The following is a description of a gene set: studied in species Mus musculus Genes containing one or more binding sites for (Rcor2) in their promoter regions (TSS -1000,+100 bp) as identified by GTRD version 20.06 ChIP-seq harmonization. Mouse Gene Set: RCOR2_TARGET_GENES from publication Yevshin I, Sharipov R, Kolmykov S, Kondrakhin Y, Kolpakov F (PMID 30445619), and this is the list of marker genes: Cox18 (NCBI Gene Id 231430), Ddx39a, Usp36, Cd63, Tesk2, Zfp810, Mdc1, Tssc4, Tmppe, Npepps, Pigc, Ccdc158, Tent5d, Prkab1, Nol11, Zfp386, H2bc11, mt-Th, Prpf4b, Hdx, Ppp1r9a, Ccsap, Gnaz, Bspry, Terb1, Cux2, H2bc4, Srrm3, Acaa2, Mbd4, E530011L22Rik, Gm8113 (predicted gene 8113), Slc7a7, Chp1, Zfp286, Fat1, 3110082I17Rik, Cckbr, Rnf130, Ddx10, Tshr, Dctn4, Dnm3, Dhx8, Atp6v1h (NCBI Gene Id 98576), Dhrs7, Tmed3, Elovl4, Arih1, Nfic, Exd1, Hvcn1, Spp1, Dhcr7, Macrod2, 4921514A10Rik, Ppil3, Clec12a, Apela, Txnl4a, Gm15912, Rnf20, Ube2e1, Ccdc174 (coiled-coil domain containing 174), Rcor2, Cenpw, Rgs2, Fyn, Acot7, Arhgef1, Ipmk, Gria2, Lncenc1, Rcan1, Ift122, Chrna9, Gm9936, Tbc1d17, Shox2, Fnip2, Depdc1a, Gpm6b, D630036H23Rik, H4c6 (H4 clustered histone 6), Ubxn6, Nrxn1, Cox15, Rbmxl2, Surf6, Hexa, Zfp764l1, Gm13034, Gm40190, Zcwpw1, Immp2l, Chd2, Ddx4, Zfp606, Zc3h8, Wsb1, Rsrp1, Snupn, Il3ra, Sorbs2, Gm20033 (predicted gene, 20033), Nif3l1, Hirip3, Mir99ahg (NCBI Gene Id 77994), Wdr81, 4930505A04Rik, Meioc, Gm16853, Prdm11, Tcn2, Ndufaf4, Pnpo, 9130024F11Rik, Selenok, Letm2, D730003I15Rik (NCBI Gene Id 98614), Gm10829, Ccdc192, Scfd2, Plpp6, Gm37885, Urb2, Stmp1, Hmgxb4, Mir6403, Creg1 (NCBI Gene Id 433375), Zfp451, Gm15728, Gm26562, Supt4a, Gm13777, Cd82, Gm42722, Wdr17, Mpp3, Cmklr1, Krr1, Gm15545, Scarna17, Ndrg1, Chi3l1, Eddm13, Ldah (NCBI Gene Id 68832), Sall4, Gm5444, Mif-ps6, Dusp23, Nek4, Otud1, Gm25867, Tram1, Platr22, Ltn1, Clec4g, Fbxo8 (NCBI Gene Id 50753), Phb1 (NCBI Gene Id 18673), 1700121N20Rik (RIKEN cDNA 1700121N20 gene), Gm31881, Cyp2u1, Eif2b3, Eid1, Klhdc4, Dnajb11, Ttyh3, Spata6l, Rpl41, Amacr, Orai2, Ccdc38, Pnkd, Smap1, Cadm4, Megf11, Gtf2e2, Gm9884, Wdr4, Git2, Ift52 (NCBI Gene Id 99173), 1700026J14Rik, Coq8a, Slx4, Usp35, Med1, Msx3, Clk4, 2410003L11Rik, Zfand4, Nbea, Pofut2, Smim12 (NCBI Gene Id 80284), Amph, Gramd1a, Lrrc36, Slc35e3 (solute carrier family 35, member E3), Fam131a, Ramac, Rgs9, Ncam2, Kbtbd12, Mrs2, Atg16l2, Tspear, Cc2d1a, Fam219b, Mir1983, Slc25a39, Paxbp1 (PAX3 and PAX7 binding protein 1), Gpc2, Aacs, Gm16318, Golm1, Gpr176, Iffo1, Cul9, Chmp1b2, Gm12762, 9530082P21Rik (RIKEN cDNA 9530082P21 gene), Flrt3, Nrip3, Tppp, 1700007F19Rik, Apba3, Ntn1, Terb2, Rpa2, Mroh6, Cxxc5, Suclg1, Mrpl44, Prcc, Mir8099-1, Sh3tc1, Plk2 (polo like kinase 2), Polr3e, Rbm44, Gstt1, Sgip1, Naa40, Riox2, Nfatc2, Parp11, Rpp14, Fuca1, Mcm3, Cops4, B4gat1, H2bc21, Btn2a2, Traf2, Rpp40, Agbl3 (NCBI Gene Id 76223), Tasor, Epg5, Timm29, Psmb3, Fam217b (NCBI Gene Id 99103), Top3b (NCBI Gene Id 21976), Furin, 4930589L23Rik, Commd4, C330002G04Rik, Plch1, Lhpp, 4930515G01Rik, Gm13135, Gspt1, Ssr2, Rbm46os, Nr3c1, Amt, Ccz1, Gadd45g, Plekha3, Pla2g15, Traip, Sema4b, Tomt, Slc12a6, Cnnm3, Mul1, Ylpm1, Dbil5, Mir423, Cimip4, Rrs1, Fstl5, Apc, 1110015O18Rik, 1110059E24Rik, Hoga1, Gm34767, Stpg2, Zscan22, Ggct, Eid2, Gle1, Zcchc24, Tbx20, Rbm47, Zpbp2, Nr6a1, Pkd2l2, Atf7ip2, Rbmx2, Negr1, Dhx40, H2bc3, Brdt, Scp2, Mpv17l2, Rc3h2, Pigyl, Nufip2, Pip4p1, Slc5a8 (solute carrier family 5 (iodide transporter), member 8, NCBI Gene Id 216225), Tmem108, Gab2, Mei1, Rnase4, U2surp, Fem1b, Rlig1, Pms2, Wipi1, Rmnd1, 1700113A16Rik, Foxa3, Abhd6, A730013G03Rik, 5430405H02Rik, Chst12, Nuak2 (NUAK family, SNF1-like kinase, 2), Map2k7, Matcap1, Coro2a, Egfl7, Syce3, Hspb6, Mapk8, Nup43, Xpnpep1, Zfp251, Lypd4, Xrcc5, Dbr1, Cntnap5b, Nr1h3, Vps13d, Lpcat3, Mdm1, Cops7a, Glis2, Naa12, 4930445N18Rik (NCBI Gene Id 77085), Gm5067 (predicted gene 5067), Zfp87, 2310030G06Rik, 4930453N24Rik, Plekhg4 (pleckstrin homology domain containing, family G (with RhoGef domain) member 4), Cdipt, Zfyve16, 1700067G17Rik, Mcoln1, Tjp1, Hlf, Slc9a5, Gm14401, Actrt3, Fmc1 (NCBI Gene Id 66117), Srcin1, Gm15903, Rab37, Trim68, L3mbtl4, Pbx3, Tmed2, Nsrp1, Fbxw7 (NCBI Gene Id 68467), Pacsin1, Ywhab, Aif1l, Psma3, Gdpd4 (NCBI Gene Id 233537), C430039J16Rik, Yipf2, Ipo7 (importin 7), Zbtb34 (NCBI Gene Id 241311), Gemin4, Stk31, Sympk, Ddx52, Ccnb1ip1, Rars1, Brat1, Elf3, Adamts10 (ADAM metallopeptidase with thrombospondin type 1 motif 10), Ptpdc1, Sacs, Grm8, Tmem220, Zfp655 (NCBI Gene Id 72611), Tuba3a, Farsa (NCBI Gene Id 66590), Chaf1b, Scg3, 1700020N01Rik, Dtwd2, Dus1l, 1700064H15Rik, Slc39a11, Spata24, Sbno1, Ang, Ttll7, Dnajc1, Hcn1, Zfp827, Apex2, Cenpc1, Nutf2, Ezh1, Sf3b1, Eapp (NCBI Gene Id 66266), Gemin5, Ube2o, Dapk3, Dis3l, Mterf1a, Prr19, Sec23ip (Sec23 interacting protein), Piezo1, Wdfy1, Pitx3, Gm15564, Dmrt1i, Gm10222, Gm12758, Irak4, Elovl2, Epop, Cyb5r2, Adamts17, Etv4, Alms1, H3c8, Stard4, Cfap44, Odad4, Focad, Zbtb44, Gstk1, Pebp1, Syn2, Smc3, Rpf1, Sgf29, Ptprs, Gm10644, Ccdc126, Hdac2, Dohh, Shcbp1l, Nlrx1, Rabgap1l, Atpaf2, 2310074N15Rik, Eif3c, A830008E24Rik, Slc25a38 (NCBI Gene Id 208638), D030028A08Rik, Vps11, H2bc18, H2ac5-ps, Dact3, Yeats4, Calm3, Gm5129, Ankrd37, Nhsl1, 1700088E04Rik, Net1, Rhof, Kank2, Rbm46, Cmtr2, Agrn, Ccdc88a, Mir8104, Heatr1, Cfap251, Ppid, Slc9a8, Gdi2, Tdrd12, Otulin, Entpd6, Izumo4, 1700112D23Rik, Faap20 (NCBI Gene Id 67513), Gm11850, Zkscan5, Boll, Fam111a, Tefm, Rfxap, Wbscr25, 1810019D21Rik, H2ac20, Klhl11, Top6bl, 3110083C13Rik, Snx1, Nup205, 5330429C05Rik, Tmco1, Mns1, Mfsd4b3-ps, Ctnnb1, Zfp791, Pprc1, Sirt6, Gm10044, Rn7s6, Nol8, Pdlim1, Fbrsl1, Dnajc16, Wdr38, Polr3a, Atxn7l1 (ataxin 7-like 1, NCBI Gene Id 72174), Zfp956, Fzd3, Pdgfra, Thap12, Mrnip, Edrf1, Bmp6, Papss1, Arhgef2, Rbbp6, Mtres1, Akap11, Gm22973, Zng1, Cmtm6, Liat1 (ligand of ATE1), Pfas, Adsl, Gorasp2, Hmox2 (NCBI Gene Id 15369), Gm11398, Pde4a, Fhod1, 2700078F05Rik, Etfa, Akr1c19, Cnppd1, Osbpl5, 3110070M22Rik, 4833412C05Rik, Mipepos, mt-Tl2 (NCBI Gene Id 17736), Nup50, Polr2f, Evi5l, Ccdc138, Gm30238, Pex6, Tex12, Cited2, Ldhc, Hdac1, Ints2, 5830411K02Rik, Arhgap21, Bcas1, Mlf1, Ift70b (intraflagellar transport 70B), Odad1, Asf1b, Uggt2, Mypop, Wdr43, BB557941, Glrx5, Esrp2, Gstm1, Smg9, Slc23a4, Zmym6, Bin2, Emc7, St6galnac4, Syt7, Ccdc115, Bambi, Adad2, Spmip4, Chkb, Gm11335, Rab3a, Pts (NCBI Gene Id 19286), Adgra2, H4c2, Ccdc83, Nedd9, Ddx43, Il6ra, B230317F23Rik, Kctd19, H2ac6, Brinp2, Gaa, Ssmem1, H4c8, Zfp335os, Snca, Suz12, Snora73a, Gm14320, Trpm8, Ube2l3, Ric1, H2ac11, Gm11635, Dhx32, 4933433G15Rik, Plekha4, Slc7a5, Stk11ip, Raf1, Gm23119, Esd, 4930558J22Rik, Obox4-ps29, Nkain2, Txndc5, Dynlrb2, Mrps9, Slitrk5, Eef2k, Gm13136, Pex10, Nans, Scarb1, Pdlim3, Msantd5l, 4632404H12Rik, Gm5464, Pcid2, Naxe, Stam, Ap1s1, Rps6ka5, Gpr155, Dot1l, Gm11346, Zbtb17 (zinc finger and BTB domain containing 17), H3c6, Shroom3, Gm10638, Rasd2, Dhrs13, Smc5, A930015D03Rik, Eif2b5, Ints8, Abca17, Gak, Wbp4, Zfp788, Zfp747, Atxn7l3b, Sox30, Anxa7, Zfp809, Rnf187, Cebpg, 3110031N09Rik, H2bc6, Smyd3, Ncan, Kics2, Ehbp1l1, Carmn, Tcerg1, Sap25, Rbpj, Gm13889, Nmt2, Naa16, Hes1, Camk1, Inpp5f, Otulinl, Rnf220, Gprin1, Tysnd1 (trypsin domain containing 1), Slc31a2, Fscn1, Fam43a, Ino80e, Atp9a, Zfp770, Strap, Zc3h14, Tcam1, Gm22984, Afap1, Gm16170, Gm42109, Lactb2, Qtrt1, Ergic3, Gm12059, Tra2a, Ly6k, Spryd4, Cmc1, A930007I19Rik, Nagpa, Gmnn, Trim44, Rptor, Lrsam1, BB218582, Trpc4ap, Rrbp1, Izumo1, Abtb3, Itgbl1, Mycbp2, Armc9, Ntrk2, Dpm1, Cstf3, Clcn3, Tmx1, Col22a1, Scg5, Cimap3, Tor1a, Gm22792, Polr3h, Dctpp1, 4921539H07Rik, Hps1 (HPS1, biogenesis of lysosomal organelles complex 3 subunit 1), Nt5m, Hccs, Bcl2l12, Epb41l4b, Nkapl (NFKB activating protein-like), Adgrb3, Myo10, 4930558K02Rik, Cd109, Fam98a, Lyrm2, Mir707, Srxn1, Kbtbd6 (NCBI Gene Id 432879), Zfp558, H3c7, Snhg3, Ston1, Msl3l2, Kifap3, Meis2, Gm16283, Anp32e, Nsfl1c, Dmrtc2, Cetn3, Haghl, Gid8, Acsf3, Tspyl5, Rhbdd2, Nfasc, Camsap2, Spop, Kbtbd11, Sgpp1, Cops8, Parp2, H2bc7, Rdh11, Ints6 (NCBI Gene Id 73038), Mmachc, Pcdhga7, Cdc23, Cntln, Glra1, Tia1, Brme1, 1700008O03Rik, Mir5100, Sdhaf4, Zfp784, Eef1e1, Rad51ap2, H4c3, Plrg1, Armt1, Tanc2, Rpph1, Akr1e1, Stom, H2ac7, Trip4, Spmip7, Gm10941, Ido2, Qdpr, Cstdc2, Zfp184, Tmem209, Nop58, mt-Tl1, Dpy19l2, Dap, Nup210l, Tmcc2, Dus3l, S100a6, Bcl2, Hyou1, Asrgl1, Gjc1, Gm28047, Epha3, Timp3, Slc6a6, Chaf1a, Platr6, Tmem167b, Whamm, Mthfsd, Epb41l4a, Jmjd1c, Cfap74, Borcs5 (NCBI Gene Id 67774), Arf4, Zfp865, Tbrg1, Tob2, Rnf114, Rdm1, Ankrd55, B3galnt2, Pafah2, Gm7626, Gm42579, Gm15587, mt-Nd1, Cdkn1c, Zdhhc6, Ctdsp1, Slc33a1, Skic8, Lrrfip1, Stc2, Bend4, Zfp532, Hsd17b11, Ank1, Nceh1, Mir1945, 1700001L05Rik, Snapc1, Fmnl3, Gbp3, Gm5141, Ccdc107, Gm36211, Ubtf, Tmem109, Ccdc15, Flvcr2, Gm57488, Cenpp, Btbd18, Psmb2, Pank3, 1700021P04Rik (RIKEN cDNA 1700021P04 gene), Fyttd1, Atp4a, Stx17, Hnf4g, Slx4ip, Gm15645, Cnot8, Ccar1, Akip1, Cacng3, Tex14, Duxf1 (double homeobox family member 1), 1700018B08Rik, Fgd4, Gid4, Vwc2l, Myef2, Znrf2, Arid1a, H4c9, Scamp5, Bcl7b, Tipin, Vhl (NCBI Gene Id 22346), Cdk20, Gtf3a, Rnf212, Glra2, Ppp1r3c, Gm16270, Ephb1, Rnasel, Asb7, Gnpda2, Pdik1l, Ndrg3, Rcbtb1 (regulator of chromosome condensation (RCC1) and BTB (POZ) domain containing protein 1), Arl8b, Pum2, Vim, Rnf227, Fbxw5, Zfp566, Ppia, Mov10l1, Dhx34, Ube2c, Eif5a2, Or4f14b, Czib, Abcc10, Zfp623 (NCBI Gene Id 78834), Mief2, Gsr, Tmed4, Oca2, Abca1, Mir191, Duoxa2, Gm14342, Dcdc5, Mael, Prdm4, Fam117a, Mob3a, Mipep, Dusp7, C330024D21Rik (RIKEN cDNA C330024D21 gene), C130026L21Rik, Sptbn1, Megf9, Flnb, Rpl37a, Phf3, Duox2, Hexim1, Dnajc24 (DnaJ heat shock protein family (Hsp40) member C24), Bambi-ps1, mt-Nd5, Pls1, Dapk2, Calcoco1, Ak8, Guf1, Atxn7l1os2, Peds1, Emc6, Mfsd1, Fance, Btbd7, Gm12494, Trbv12-2, Tmub1, Mob3c, Ncam1, Rab5if, Rbm19, Pipox, Ddx19b, Podxl2, Patl2, Dab1, 1810019N24Rik, Pgam1, Dnajb6, Mapk6, Eif3f, Ipp, Gm2287, Zfp128, L3mbtl2, Cse1l, Dgat1 (NCBI Gene Id 96948), Cntnap2, Rplp2, Ccdc90b, Tspyl1 (NCBI Gene Id 22110), Imp4 (NCBI Gene Id 98620), Jarid2, Gm29257, 9230009I02Rik, Ppa2, Gli1, Cdv3, Dld, Zpr1 (NCBI Gene Id 22687), Gm28513, Meis1 (Meis homeobox 1), Rad50, Glb1, Zfp747l1, Tcte2, Spaca9, Npy1r, Stk11, Trpv4, Hectd3, Trp53bp1, Ciart, Casp8ap2, Pigz, Mdm4, St8sia4, Klhl35, Tmem38a, Ivd, Slc6a9, Arcn1, Mir6236, Vps37d (NCBI Gene Id 194309), Mkrn2, Gins3, Lrrc2, Vpreb1a, Snai1, Pdcl3, Bach2 (BTB and CNC homology, basic leucine zipper transcription factor 2), Hilpda, Ripor2, Zfp990, Ap1m1, Lrrc3b, Pagr1a, Rcc1, Rnf141, Syt12, Atic (5-aminoimidazole-4-carboxamide ribonucleotide formyltransferase/IMP cyclohydrolase), Ndufaf3, Arhgap18, Trabd2b, Tnfaip3, Gm17399, mt-Ts2, Arhgap23, 4930583I09Rik, Spic, Fggy, Dop1a, Slc25a40, Baiap2l1, Grwd1, Ash2l, Dync2i1, Coa6, Pstpip1, Adnp, Insc, mt-Nd6, Mir148b, Stx4a, Myl4, Abca3, Nr2c1, Fgfr1, Zfp696 (zinc finger protein 696), Iars1, Nkx3-1, Mgrn1, Gpcpd1, Zbtb43, Akr1b1, Ppm1h, Gm8066, Uba2, Fbxw4, Unc79, Tiprl, Dpp9, Ube2e2, Ddb2, Zcchc8, Cutc (NCBI Gene Id 66388), Klhl7, Kif5a, Zfyve26 (NCBI Gene Id 77517), Rfc5, Wdcp, Sfi1, Smim45, Tasor2 (NCBI Gene Id 105203), Uqcc2, Egf, Bltp2, Cul4a, Idh1, Caprin2, Ccdc167, Ctnna3, C8g, Gpat2, Acp6, Acp2, Abca2, Taf13, Elof1, Pgm2, C1rl, Tpgs2, Gm17733, Tdh, Psen2, Slc26a2, Rnf125, Arf1, Mrps30, Pfn4, Ildr2, Kdm6bos, Bdh2, Ankrd39, Arid3a, H4c14, Prkcd, Cpsf1, Ino80b, Sh3bgrl2, Hsd17b14, Pik3r2, Parp3, Mcph1, Retreg2, Tex19.1, Crls1, Slc44a1, Trim2, Rph3a, Trpm7, Rrp9 (NCBI Gene Id 27966), Gtf2f2, Gm5091, Agfg1, Mtf2, Fbxo27, mt-Te, 1700057H15Rik, H2bc27, Gpc6, Dock1, Vps33a (NCBI Gene Id 77573), Lrrc71, Snhg7os, 4833445I07Rik, Mlxip, Csrnp2, Syce1, Dlgap5, Ticam2, 4930519G04Rik, Dpysl3 (dihydropyrimidinase-like 3), Stag3, Gm19705, Snora17, Tmem175, Tubgcp3, Acrbp, Rev1, Zmat5, Cox5b, Ercc6, Rnd1, Thumpd1, Lonrf1, Dgat2, Phyh, Gmpr, Tnfrsf21, Zfp280d, Naf1, Gm10610, Pfn3, Tax1bp3, Ccdc163, Diaph2, Laptm5, Disp2, Mafk, Mllt6, Nolc1, Trim13, Fut10, Capzb, Atp6v0e2 (ATPase, H+ transporting, lysosomal V0 subunit E2), Dhrs7b, H4c4, Fkbp6, Atf7, Cox7a2, Map4, Pramel12, Gm11205, Cul2, Mrps28, Gcfc2, Rheb, Tjp2, Ilf3, Utp20, 6820431F20Rik, Zfp367, St6galnac6, Lins1, Igsf3, Rpl7l1, Nup54, Lmbr1l, Iqsec1, Stard13, Zbtb32, Cir1, Timm13, Tsen2, Rps15a, Snx15, Pitpnm3, Gm12257, Mettl2, B230207O21Rik, Clu, 4921504E06Rik, Slc2a6 (solute carrier family 2 (facilitated glucose transporter), member 6), Camk2d, Ppp1r12c, Tle5, Polr2e, Ttc28, Aloxe3 (arachidonate lipoxygenase 3), mt-Tt, Mepce, B230219D22Rik, Ube2q1, Rmdn1, Zcwpw2, Mien1, 9330198N18Rik, Ccdc134, Bbc3, Irf3, Akt1s1, Psat1, Uqcr10, Mir3063, Hapln4, Osbpl10 (NCBI Gene Id 74486), Smim7, Hormad1, Tsn, Tomm20, Azi2, Gm15477, Gm16066, Med16, Mbd1, Rab8a, Kctd7, Utp23, Cep44, Rnu1b2, Trnp1, Mtmr7, Cdiptos, Snx8, Dnttip2, Ccdc78, Exd2, Gm14393, Setd1a, Upp1, Tbccd1, Satb2, Arhgap27, Akt3, Mapre2, Cct2, Tex15, Uxs1, Micu2, 4931415C17Rik, Henmt1, Ndn, Gm13783